Given this list of marker genes Polg, Polq, Pola1, Dntt (deoxynucleotidyltransferase, terminal), Primpol, Polh, Poln, Pold4, Polg2, Rev1 (NCBI Gene Id 98573), Polk (NCBI Gene Id 27015), Chrac1, Pole (NCBI Gene Id 18973), Pold1, Polb, Poll, Poli, Rev3l, Pold3 (polymerase (DNA-directed), delta 3, accessory subunit), Tent4b, Polm, Pola2, here is a description of the gene set: Catalysis of the reaction: deoxynucleoside triphosphate + DNA(n) = diphosphate + DNA(n+1); DNA-template-directed extension of the 3'-end of a DNA strand by one nucleotide at a time. species: Mus musculus Mouse Gene Set: GOMF_DNA_DIRECTED_DNA_POLYMERASE_ACTIVITY